Given this list of marker genes FOXN3 (forkhead box N3), EPHA3, FOXL2NB, SOX6, SLC52A2, ADGRB2, LARP6, FOXI2, TCF20, ZNF626, CCK, IL5RA, CELF4, CD96, NKAIN1, UBA3, REL, CDC42BPB, THRB, NSUN5, PHF20L1, HLTF, MDGA1, GOLGA1, RFX4, DPP4, FOSL1, ATCAY, CCDC88C, EEF2K, WDR19, NRN1, GALNT3, TRIM68, NSD2, CAPSL, L2HGDH, CYP2S1, EVX1, RGMA, IDH1 (isocitrate dehydrogenase (NADP(+)) 1), MKRN1, NT5C3A, TEAD1, GET3, RSC1A1, FAM221B, IGDCC4, BTBD7, CCDC141, ARFGEF1, RNF114, S100A12, C11orf96, ST8SIA4, NSD1, ZNF589, MORF4L1 (mortality factor 4 like 1), ONECUT2, ZNF578, DAZL, POGLUT3, MS4A7, PRADC1, LRIT1, MIS12, NEBL, RERGL, SEMA7A, DGKG, CCDC70, MYCBP, INSYN2B, VWA5B2, SHISA9, EEF1AKMT3, USP44, CALCOCO1, KALRN, DDB1, KATNAL1, CALML4, here is a description of the gene set: Human Gene Set: MIR574_5P studied in species Homo sapiens Genes predicted to be targets of miRBase v22 microRNA hsa-miR-574-5p in miRDB v6.0 with MirTarget v4 prediction scores > 80 (high confidence targets). from publication Chen Y, Wang X (PMID 31504780)